Given this list of marker genes STRN4, PPP2CA, PPP2R1A, STRIP1, SLMAP, MOB4, STRN3, STRIP2, PDCD10, STK26, STK25, SIKE1, PPP2CB, STK24, CTTNBP2NL, CTTNBP2, STRN, here is a description of the gene set: studied in species Homo sapiens A conserved protein phosphatase type 2A complex which contains a protein phosphatase type 2A, a protein phosphatase regulatory subunit, a striatin, an FHA domain protein and other subunits (at least six proteins). In fission yeast this complex negatively regulate the septation initiation network at the spindle pole body. Human Gene Set: GOCC_FAR_SIN_STRIPAK_COMPLEX